The following is a description of a gene set: Human Gene Set: LET_7A_3P studied in species Homo sapiens Genes predicted to be targets of miRBase v22 microRNA hsa-let-7a-3p in miRDB v6.0 with MirTarget v4 prediction scores > 80 (high confidence targets). from publication Chen Y, Wang X (PMID 31504780), and this is the list of marker genes: TMED7, FGFR2, SPOPL (speckle type BTB/POZ protein like), ANO5, KRBOX4, STON2 (stonin 2), ARHGAP44, GATA3, CACNA1C, WNT5B, PHC3, FLT3LG, CARF, ZNF292, SPAST, LIPG, CEP57, GPR37, HNRNPD, TGFB3, AASDH, TEAD1, EDIL3, ZDHHC20, TM4SF4, ITGA6, LIN9, SDC2, RFX1, TASP1, PECR, KIF2A, DAAM1, EBF3, MIF4GD, PALS2, HSPA14, VAV3, ZFYVE21, CCNE2, LRRTM4, PRDM16, MNX1, C1QBP, VAPA, FSHB, TRHDE, ANKS1B, TAF4B (TATA-box binding protein associated factor 4b), PI15, CYP7B1, CCDC126, SCAMP1, PANK3 (NCBI Gene Id 79646), ROCK1, MLLT6, ARID4B, MED14, CALN1, CLASP2, MRPL44, STK40 (NCBI Gene Id 83931), PNISR, BDNF, SCN2A, HECTD1 (NCBI Gene Id 25831), RALGDS, PARPBP, SCAI, DCAF7, APPL1, GOLIM4, RSRP1, GTF2A1, SPESP1, IGFBP1, DKK3, FNBP4 (formin binding protein 4), SCX, PRKAA1, DR1, FBXO33, SUN1, NRP2, GIGYF2, THAP12, ZNF780A, ID4, NUDT12, QKI, TRA2A, DENND2B, MYCN, CHD1, LILRA1 (leukocyte immunoglobulin like receptor A1), VMA21, DCC, BLTP1, RORA, HIP1, UBE2Q2 (ubiquitin conjugating enzyme E2 Q2), ATP6V1H, TCF3, YY1, MEF2D, CECR2, MBNL2, ERF, AFF3, MPC2, LRP1B, RPRD1A, DNAJB5, SET, RAB3GAP2, HYCC1, RHOA (ras homolog family member A), NADK2, RAB10, UNC119B, RELCH, SLC4A5, SEPTIN9, E2F5, HOXA9, CCL7, MEX3B, NUFIP2, OTUD4, AHR, UBE2H, EFR3A, B3GLCT, UBR1, TBR1, TET2, CMPK1, OXR1, ZFPM2, USP12, MARK1, PARD6B, ULBP1, ACVR1, LIX1L, USP34, CADM1, GUCY1B1, ARID1B, ZNF569 (zinc finger protein 569), DOCK1, BLOC1S4, CREBRF, GRHL3, CLDN12, REV3L, HES1, TVP23C, PRPF38B, ARHGAP12, FZD6, NPY1R, KPNA3, SNAPC1, BCAP29, GDAP1, FAM76B, BRD1, LYPLAL1, DCAF6, IREB2, PPP4R3B, PHIP, ZIC1, SOX9, MBNL1, SPRED1, EPS15L1, JPH1, POU2AF3, ATAD5, FGD6, PDLIM5, AGTR1, LEMD3, TMEM87A, PUM1, NECTIN1, SAMD12, RDX, PLAG1, KCNJ15, BCL6, RPRD1B, DOP1A, BTF3L4, AKAP12, KLF2, PHACTR2, COL19A1 (collagen type XIX alpha 1 chain), TNS3, DGKH, RASEF, FAM3C, MAN1A1, PPP4R2, COG7, DENND1B, RAB11FIP3, UBE2B, RAD21, OPA1, AMMECR1, HERC2, IFT70A, ZNF800, NF1, GRK5, HTR2A, RAB14, PIK3R4, MLLT10, C11orf54, AKTIP, NAA20, EIF4G3, TIGD7, POLR2K, CNOT6L, NRBF2, PLEKHA6, ASB11, CHD3, AAK1, ZFYVE16, RAPH1, UBQLN1, MBLAC2 (metallo-beta-lactamase domain containing 2), DCUN1D4, C18orf63, GNAI3, DACT1, SYF2, GRM3, BTAF1, ZNF518B, NUDT11, TGFBR3, RAB11B, CNTN1, KLHDC2, KIF11, UBN2, LYSMD3, WWC2, BRWD3, EIF1AD, ATF2, ANK3, PSD2, ANKRD44, SRP9, BAG2, DENND4A, GOLGA2, TFRC, USP24, TLE4, TMTC4, UBFD1, STK38L (NCBI Gene Id 23012), RABGGTB, ARFGEF2, CLIP1, RAB6D, ACTL6A, FBXL3, LIN54, RNF24, ANAPC13, XPO1, RIF1, ZNF430, PEX5L, PFKFB3, CFTR, KBTBD7, CTR9, PRR12, PDE10A, DLX2 (distal-less homeobox 2), TUT4, GNA13, ULK1, GLCCI1, WWC1, IER5, TET3, KDM2B, LY75, ITCH, FAT3, PPP3CA, TBC1D2B, FSCN1, DLL1, N4BP2, PUM2, WAC, APOOL, CPEB2, GSK3B, LGALSL, PPFIA2, ITM2C, ZMYM4, F2RL1, CCDC102B, ACTR3, NFYB, DERL1, TRIM63, PRRC1, F3 (NCBI Gene Id 99486), ELAVL2, MED6, GRM5, NR4A3, ZMIZ1, CIAO2A, IRX3, RHOBTB3, PPP1R2, ELOVL7, TLE1, EMP2, KIN, LAMP2, E2F8, VEZF1, KIAA0408, LGR4, SATB1, FSTL5, DLL4, C5orf58, DSG2, NEUROG2, ACTR3C, CEMIP2, BTNL9, HECTD2, NR5A2, NOL4, FREM2, KDM7A, SLC6A14, STK24, C1QTNF7, SPEN, UBE2W, ARHGEF33, OLFML2B, SMARCA2, FOXO1, UBN1, SP8, ADRB2, MMP20, KLF12 (KLF transcription factor 12), PPM1D, TAF2, TAFA4, ZC3H11A, ALKBH8, SNCAIP, RAB6B, NDC1, MINDY3, OTUD6B, ZMYM6, FOXN2, FOXP1, CLOCK, PDZRN3, AP1S3, C7orf57, MAP2K3, RNF180, TRGC1, ZFY, HIVEP2, MTF1, BST1, CRY1, SRSF2, AKAP13, LRRC4, ERI1, INO80D, RHOT1, EFNB1, SLC18A2, JAG2, WASF3, ARHGEF28, TTF2, ST8SIA4, EEA1 (early endosome antigen 1), EPHB4, WDR26, CENPE, AKAP9, RNF149, SEMA3C, SV2B (NCBI Gene Id 9899), SCN7A, VCL, PTER, DYNC2LI1, USP32, CDH20, AUTS2, MON2, GNB4, ATL1, UTRN, MYCBP2 (MYC binding protein 2), CDC7, SRSF1, NUP58, CDK19, FNDC3B, FBXO43, MMS22L, IMPACT, PCDH8, CLDN16, LATS1, SLC6A17, PIAS1, SORBS1, CILK1, SH3GL3, DCLK3 (NCBI Gene Id 85443), PHYHIPL, SYNGR3, IGF1R, DPM1, PPM1A, PLPP3, FBXO45, ARIH1, TAOK1 (TAO kinase 1), FBXO34, KLF3, HNRNPA2B1, ITM2B, EGFL6, COL1A2, SEPHS1, GPR158 (NCBI Gene Id 57512), NLGN1, COL4A1, ARHGAP20, SOS2 (NCBI Gene Id 96829), DCBLD2, CLDN1, RIMKLB, NGDN, RBPJ, RBM12B, GULP1, CAMTA1, MAST4, CTU2, SLC6A11, BMAL1, MTARC1, CUL1, CNOT6, ZNF827, ITGAV, HEATR5B, ELK4 (ETS transcription factor ELK4), NR3C1, TRIM6 (tripartite motif containing 6), LCOR, CRACD, NKTR, NUP98 (nucleoporin 98 and 96 precursor), DOCK11, PCSK2, ZNF326, RAB11FIP2, TVP23B, AKAP10, SP4, DACH1, NCKAP1, POLR1F, YTHDF3, IKZF2, NASP, NPY, SGTB, ZNF302, RIPPLY2 (ripply transcriptional repressor 2), CCNA2, ADAM28, FBLN5, FBN1, MARCHF6, COL11A1 (collagen type XI alpha 1 chain), USP25, CEP41 (centrosomal protein 41), SRBD1, FRS2, GLS, GNAL, GPRIN3, PPP1R3F, ZNF236, ASAP2, PTBP3, SMARCA5, NAA25, LRRC32, MALT1, CERT1, KDM6A, TCF20, TSHZ3, BMPER, GNAQ, SFPQ, PEAK1, TMTC2, SPTB, SBF2, NRP1, RSF1, USF3, SPINDOC, TAS2R14, PPM1L, CPNE2, CTTNBP2NL, HS6ST2, ELOVL2, BTBD3, MSANTD2, KIF3A, PSIP1, FGF7, C11orf58, GTF2I, PAK2, PPP1R21, PPP1R15B, PTMS, EIF4ENIF1, CTNNB1 (catenin beta 1), DMTF1, NUP35, FAM204A, DDX21, MAGI1, CWC22, PRDM2, KMT2C, SOWAHC, PIKFYVE, FAM117B, ID1, HOOK3, MATN2, CEP76, ZBTB14, UBL3, MAP2, ANO4, UBTF, LSM14A, ICE1, ARAP2 (NCBI Gene Id 23278), SRSF11, RPS16, ACVR2B, TRAK1, ATG2B, NUDT4 (nudix hydrolase 4), CACNA2D1, B3GNT2, OLIG3, ASAH1, PTCH1, CNNM4, LTN1, CAB39, SDHAF3, MAPKAPK5, JAG1 (jagged canonical Notch ligand 1), PAN3, SPRY2, FYTTD1, SLC34A2, SLC39A6, TMEM132B, KDM5B, SECISBP2L, MYT1L, HMGXB4, TCERG1L, LRP6 (LDL receptor related protein 6), GDAP2, BRF2, SLC35A3, NBEA, NCOA2, SPOCK3, TRPM7, PLCL2, ATRX, KIF21A (NCBI Gene Id 80819), DNALI1, PIK3C2A, YTHDC1, DCLRE1B, FUT9, BHLHE40, ALDH1L2, HNRNPA1L2, MEF2C, GRIA3, LRRC1, KRAS, ZBTB39 (zinc finger and BTB domain containing 39), CASP8AP2, RNF138, AKAP6, ZNF367, SLC39A10, LHFPL3, SEC22C (NCBI Gene Id 9117), PRPF8, ETS2, OTX2, UBE3C, SPRY1, RC3H1, UBXN7, HYCC2, KIAA1217, CCDC186, TSLP, APP, GABRG1, HIC1, RNF216, ISM1, RBM22, ZNF506, U2SURP, GTF3C3 (NCBI Gene Id 9330), MMAB, NFAT5, CORO1C, HNRNPA1, SELENOK, THRB, SALL3, SHOC2, FA2H, SLAIN2, RTN1, WIPI1, PAXBP1, MECOM, GP1BA, CCNY, PTPRE, SCARF1, CEPT1 (NCBI Gene Id 10390), DOCK10, IPMK, SGO1, ABI1, JAK2, ARID4A, BMPR2, SLC6A4, FNDC3A (NCBI Gene Id 22862), CREBZF, L3HYPDH, CRISPLD1, ZMYND8, KLF4, POU4F2, PSD3, ACBD3, DNPEP, BAZ1B, BASP1, EIF4A2, FRMD6, BMP3, KLHL2, NR2F2, CEP192, BRIP1, SLC2A13, CD38, LRCH4 (leucine rich repeats and calponin homology domain containing 4), CPEB3, TOB1, HMGCR, FRMD4B, RICTOR, NAA16, RAB2A, DUSP6, HIPK3 (homeodomain interacting protein kinase 3)